Given this list of marker genes KLHL24, MITF, TFEB, CEP85L, GLT8D1, EEA1, FZD4, IRF2BPL, PCSK6, FRMD8, PRDM13, CRTC3, CNTN1, RASSF5, LRRC1, RFX3, ACSL1, ASPA, TWSG1, DNASE2, SCAF11, NME4, MKX, ANKRD44, MAN2A1, PAPOLG, PECR, THRB, PRKAG2, FLRT3, SEMA6D, GCH1, JADE1, CAV1, NFATC2, SLC1A4, ERN1, SGCZ, MYZAP (NCBI Gene Id 100820829), NR5A2, SIGMAR1, SLC17A5, RALGDS, SAP30L, SCD, ALDH1L2, COL4A1, PLSCR3, OSBPL10, STK35, TTL, PI4K2B, CALCOCO1, PEA15, MGAT4A, CYB5A, SCAMP4, ATP6V0E1, BLOC1S6, SLC35B2, CAPN6, CCDC86, LMAN2L, CADPS, SSH1 (slingshot protein phosphatase 1), GGA2, HECTD2, SUMF1, PRLR, ACTN4, ITGA3, PLEC, CLOCK, CDH4, TRIM48, PSKH1 (protein serine kinase H1), EYA2, GATA6, WASF1, MICAL2, MINAR1, FAM53B, TPST2, KIAA2013, CBX2, C2orf68, SLC16A1 (NCBI Gene Id 6566), MARCHF8, ZMPSTE24, BCL2L13, LAMC1, C2orf69, CBL, TNFSF15, DENND6A, GPATCH8, HIVEP2, CAPN2, PDPR, GRIA4, SLC31A1, RGS9, TJP2, PAQR9, RHOG, GDAP2, NFAT5, LPP, SNX16, HADH, OSBPL3, RASSF3, H6PD, PROX1, AMOTL1, NCOA4, GGPS1, THSD7B, GRIA2, NYNRIN, P4HA1, PML, PARP16, SUCLG2, PDLIM5, TWIST2, THBS2, TMBIM1, NEURL1B, SHANK2, SESTD1, TSKU, STK38 (serine/threonine kinase 38), EPS8, ABCC4, EVI5, SEPTIN9 (NCBI Gene Id 8162), SLC44A5, PDE4B, CGN, DLL4, TRIM49 (NCBI Gene Id 82890), CDCA7 (cell division cycle associated 7), NFIC, MEF2A, DUSP3, CBFB, PCDH8, MED26, SFT2D2, G3BP1, ITGA7, HIPK3, PALLD, CHIC2 (NCBI Gene Id 26511), NTAQ1, ECI2, TMEM104, FAM199X, PPP1R13L, NEMP1, TMEM150A, BICC1, LIF, PLEKHH1 (NCBI Gene Id 57475), FSTL5, SLC16A13, MBOAT2, CHODL, RNF135, IFFO2, BACH2, RNF128, TMEM184B, SVIP, SORD, RAVER1, LAMP2, TNFRSF11B, MTMR10, SNX18, SGPL1, APBB2, ZBED4, KCNK10, NR3C2, SMOX, DLX5, RNF217, XKR6, SNIP1 (Smad nuclear interacting protein 1), CNKSR3, PTPRJ, AMMECR1, FLOT2, EML6, ENY2, KIF13B, PIK3C2A, MAPK14, MAGT1, KIF3A, DYRK2, POGLUT1, NEK6, MTCL2 (microtubule crosslinking factor 2), WIPF3, CTDSP1, VAT1, PRKG1, GMCL1, E2F5, KCTD8, EPHA3, RAB27A, RIF1, STON2, RBM33, PABIR2, ST3GAL1, TBX22, SEC13, BMP6, CCDC177, PGRMC2, RFFL, JAM2, SGMS1, ILDR2, OVOL2, TLL1, SLC9A9, STK26, NAP1L5, DLX3, LIMS1, GRIA3, ZNF706, MLXIP, FURIN, PABPC4L, ASB4, CLMP, XYLT1, GLCE, PLOD3, SH2B3, SDF2L1 (NCBI Gene Id 23753), KCNJ6, WIPF2 (WAS/WASL interacting protein family member 2, NCBI Gene Id 162601), CHIC1, VPS35, CDK6, ANXA5, HDAC4, TBC1D9B, KIF26A, PLXNB2, SERTAD3, ROCK1, GNG2, MAP3K1, EYA3, DNAJC1, TET1, PARD3, FAR1, SNAI2, BCL11B, FCHO2, PRRX1, TMEM109, ZBTB20, PPARA, ASCC2, PLXNA3, AHR (aryl hydrocarbon receptor), GPALPP1, SPPL2A, SOS2, IMPACT (impact RWD domain protein), ECE1, RASGEF1A, LMBRD1, NFIB, HIPK1, CREBRF, IPO8, LCP1, ZMAT3, SMCO4, RAB22A, ANXA7, ZFP36L1, CCDC28A, CDH9, AMOT, TP53INP1, YME1L1, LDLRAP1, RAD17, HEBP2, SLC13A1, FKBP15, NFIX, TADA2B, SMAD5, CLDND1, RAI14, RPS6KA1, TRAF3, PIP4K2C, ZFP36L2, ARHGEF37, SREK1, PLP2, DCTN4, FNBP1, ESYT2, LUC7L2, RASSF8, RPIA, MTM1, UBE2G1, SLC22A5, SLC39A9, NFATC1, PHF8, ARMC1, GMNC, B4GALT1, KIF2A, ULK2, PARP14, NAA15, NAPEPLD, ZSCAN22, PPIF, MOCS1, PLEKHF2, GMFB, ANXA11, CTDSPL, ELOVL5, C9orf72, PRTG, TTC7A, ALDH9A1 (aldehyde dehydrogenase 9 family member A1), PARP8, NSUN2, TSC22D4, MIB1, CTNND1, PIM1, PTPRD, SRGAP1, PTPRQ, ABT1, OSBP (NCBI Gene Id 5007), GOLM2, ZNF219 (zinc finger protein 219), RAB3GAP1, VIM, CYP2R1, USP2, SLC30A7, SERINC2, LRRC58, SLITRK6, CPNE3, SMARCC1, PLEKHM3, SPTLC1, GARIN1A, C1GALT1, CELSR1, TUB, ZDHHC3, ELL2, RFX4, RHOU, ZWINT, RYR3, GNG10, ROR2, FAM78A, CPNE5, SERTAD2, ARHGAP28, RREB1, TMEM178A, SERP1 (stress associated endoplasmic reticulum protein 1), ITGB1, CPD, TNRC6B, SBNO2, TOR1AIP2, CASP9, ARFIP1, EFCAB14, LPIN1, TRIM49C, EYA4, HIVEP3, ATF7, STX10, ANTXR2, FLOT1, SEMA6A, FSBP, LRRC57, MIGA1 (mitoguardin 1), FMOD, LCLAT1, GPR37, RARG, QSER1, KLHL28, SHC3, BPNT2 (3'(2'), 5'-bisphosphate nucleotidase 2), CDCP1, TMC7, PNPLA2, IQGAP2, PIEZO2, RAB11FIP1, SPINDOC, USP1, JAKMIP3, PAM, KLF6, PTPN9, TLN1, IL6R, OAF, AP1M2, CPA3, FAM177A1, PHACTR2, EGR2, ORC2, RAPGEF1, PPM1F, HMGXB4, MYH10, PHF19, RAB34, RYK, SHC1, DNAJC25-GNG10, SUSD6, SLC7A14, TMEM87B, WASF2, SLCO5A1, CCDC198, SRSF6, ATF7IP, TSHZ1, CDK13, FAM171A1, LRIG1, RBM47, MYH9, USP45, UBE4A, RELA, FA2H, UNC5D (NCBI Gene Id 137970), SCAMP2, SLC31A2, UNC119B, FBXO38, PPFIBP2, DSG2, OGFOD3, ITPR3 (NCBI Gene Id 3710), BCL7A, C2orf88, PTPN14, SLC25A37, ZNF608, TRAM2, CUL5, KCNK2, KPNA3, FCHSD2, ELK4, TRIM45, ZNF503, KIAA1671 (NCBI Gene Id 85379), SNTB2, SH3KBP1, HTATIP2, ZNF131, NID1, GRB2, TRIB3, SLC25A39, RAPH1, CEBPA, ETS1, MYRIP, GRID1, RCOR1, PUS10, JAG1, ERMP1, EDEM1 (ER degradation enhancing alpha-mannosidase like protein 1), LITAF, SNTA1, KLLN, IL9R, FERMT2 (NCBI Gene Id 10979), FPGS, PDCD6, FRMD6, ACAA2, MYLIP, SNAP29, ENDOD1, RSRC2, ENAH, MYO1E, UBE3A, SP1, BTBD10, RANBP10, SGK1, SPOPL, DDX3X, RWDD4, SLC2A13, PPP1R3B, PTTG1IP, GNAI1, CDH2, KIF26B, FRMD4B, SLC35A4, GALNT10, VAMP3, SLITRK4 (NCBI Gene Id 139065), EGR1, TOR3A, RBM24, GIT2 (NCBI Gene Id 9815), GDAP1L1, CD151, EYA1 (EYA transcriptional coactivator and phosphatase 1), L2HGDH, DMD, GFPT2, AIF1L, SLC25A38, LIMCH1, DMRT1, FARP1 (NCBI Gene Id 10160), ADNP2, ZBTB11, RAB10, EDNRB, STEAP3, WTAP, USP30, SLC35G1, SOX8, RAB3D, FAM78B, KATNBL1, NMNAT1, SLC66A3, RAB38, TMED1, MTR, MYADM, RRAGD, SNX30, SMARCAD1, CPT1A, ATL3, TARBP1, APLN, MYO1C, TMEM248, AKT1S1, SH3PXD2A, FOXQ1, CACUL1, C2CD3, GCDH, ZCCHC24, RBL1, TRIM49D2, SLC7A1, POLR3G, SYT14, ARL5B, SLC10A7, REEP1, MYRF, FAM120C, TRIM49D1, IAPP, RHOQ, HIVEP1, ZKSCAN4, ARHGDIA, WDR48, ATP6V0A2, USP14, RXRA, MORC4, RBM20, STT3A, AKT3, PTPRZ1, VPS37C, PAPSS2, GNAL, MYO10, ACADVL, LPCAT3, PGM2, CSPP1, PTBP2, CASQ2, GTF2A1, ABHD5, HADHA, HIF1AN, PTPN12, MANBAL, GPAM, RDH10, SLC25A30, EIF3B, NR4A1, ADCY9, HEATR1, BCAT1, NECAP2 (NECAP endocytosis associated 2), TMCO3, CCDC89, CD164, ELAPOR2, GALNT13, ALG2, MCUR1, PAQR8, RAD54B, TFDP2, SEPSECS, YEATS2, KANK1, IQGAP1, CERS2, RYR1, TMEM41A, LEMD3, ATP7A, CHP1, SLC33A1, PKN2, ATP1A1, NRP1, FMC1-LUC7L2, TMEM134, RIOX2, SERTAD4, OSBPL11, GSN, RALGPS2, SUCO (SUN domain containing ossification factor), SIX4, RALA, ANAPC7, KATNA1, UBQLN3, RHBDF1, PTBP3, CREB3L2, PHKA1 (NCBI Gene Id 5255), ETNPPL, SLC50A1, CHST14, ENPP4, IREB2, ANKRD27, AFF4, RNF19A, TMEM35B, WDR44, ATMIN (NCBI Gene Id 23300), DMRTA1, WDFY3, SELENOI, TEAD1, STOM, WNK1, CXADR, OSBPL8 (oxysterol binding protein like 8), CHST1, SVIL, TEX261, MBNL3 (NCBI Gene Id 55796), GZF1, SLC15A4 (solute carrier family 15 member 4), SGPP1, PTBP1, SLC9A2 (NCBI Gene Id 6549), RBMS3, CC2D1B, CAPN1, GPT2, THAP2, CTDSP2, MYORG, SEPTIN10, ELK3, QKI, SPCS2, NIBAN2, GLRB, RAB11FIP5, CNEP1R1, CUX1, RYR2, MAPK4, GXYLT1, ANKLE2, NAT8L, WIPF1, MAP3K2, KAT7, CHSY1, RNPEPL1, ARFGEF2, GLI3, CDON, DENND1B, ITPRID2, SUGT1, XPO4, RBMS1, POC1B, MYH11, ZKSCAN8, here is a description of the gene set: studied in species Homo sapiens from publication Chen Y, Wang X (PMID 31504780) Genes predicted to be targets of miRBase v22 microRNA hsa-miR-506-3p in miRDB v6.0 with MirTarget v4 prediction scores > 80 (high confidence targets). Human Gene Set: MIR506_3P